Given this list of marker genes FCAR, CNN2 (NCBI Gene Id 1265), UBR4, GGH, SLC2A5, ATP8B4, QSOX1, RAB27A, RAP2B, CYFIP1, PTPRB, TMEM30A, C3AR1, NFKB1, STK10, LCN2, MOSPD2, AP1M1, LRRC7, SLCO4C1 (solute carrier organic anion transporter family member 4C1), ITGB2, OSCAR, DEGS1, TMC6, PDXK, TMEM63A, LTF, TARM1, DNAJC5, HMOX2, AGPAT2, VAMP1, ILF2, RAP1A, CD53, CKAP4, CD33, SLPI, SCAMP1, TCN1, TSPAN14, PTPRJ, SNAP25, MMP8, CTSZ, CD93, CYBB, ITGAV, PTX3, DNASE1L1, CLCN3, ARG1, TNFRSF1B, DEFA4, STX4, STX3, LRG1, SPTAN1, HGSNAT, ACAA1, TMBIM1, CD177, AOC1, PTPN6, TOLLIP, FRK, CLEC4D, MS4A3, ORMDL3, NEU1, CEP290, CD59, ALDH3B1, CHI3L1, PLAU, ORM1, CD47, PRG3 (NCBI Gene Id 10394), MCEMP1, ORM2, CEACAM8, RETN, ADAM8, DOCK2, CEACAM1, CD36, GPR84, ITGAM, LAMTOR1, VAMP8, PLD1, LAIR1, SLC27A2 (NCBI Gene Id 8523), ARMC8, CFP, PLAUR, CRACR2A, BST1, TIMP2, STXBP3, ANXA3, LAMTOR2, KCNAB2, CAMP, PGLYRP1, SLC15A4, SNAP23, CHRNB4, MMP25 (matrix metallopeptidase 25), OLR1, TOM1, CMTM6, ATP8A1, CLEC12A, ATP11A, LAMTOR3, CLEC5A, RAB37, ERP44, LILRA3, TRPM2, RAB44, HPSE, CTSD, ADAM10, ADGRG3, ELANE, BPI, KPNB1, HP, ATP6V1D, FPR2, CXCL1, CHIT1, GHDC, B2M, P2RX1, ANXA11, OLFM4, DGAT1, JUP, NIT2, SLC44A2, MLEC, CEACAM3, PGRMC1, STXBP2, FOLR3, CYBA, CRISP3, CANT1, GSDMD, ANO6, HVCN1, QPCT, SLC2A3, VCL, ITGAL, LYZ, STOM, here is a description of the gene set: Human Gene Set: GOCC_SPECIFIC_GRANULE studied in species Homo sapiens Granule with a membranous, tubular internal structure, found primarily in mature neutrophil cells. Most are released into the extracellular fluid. Specific granules contain lactoferrin, lysozyme, vitamin B12 binding protein and elastase.